The following is a description of a gene set: species: Homo sapiens The chemical reactions and pathways involving glucosamine-containing compounds (glucosamines). Human Gene Set: GOBP_GLUCOSAMINE_CONTAINING_COMPOUND_METABOLIC_PROCESS, and this is the list of marker genes: CHST1, CHST5 (NCBI Gene Id 82922), CHI3L1, MGAT3, GNPDA2, CHST7, CHIT1, PGM3, GNPDA1, AMDHD2, NANP, OGA, CHST3, CHST4, EXTL2, HEXB, CTBS, LARGE1, CHST6, CHI3L2, GNE, CHST2, CHIA, OVGP1, NAGK, RENBP